Given this list of marker genes Rpl6l, Rpl36a, Rpl39l, Rpl11, Rpl34-ps2, Rpl31, Rpl22, Rpl18a, Rpl36, Rpl8, Rpl32-ps, Rpl39, Rplp2-ps1 (NCBI Gene Id 676643), Uba52-ps, Rpl21, Rpl9, Rpl14, Rpl38, Rpl41, Rpl34-ps1, Rpl5, Rpl13-ps6, Rpl10-ps3, Rpl10, Rpl36al, Rpl24, Rpl3l, Rpl4 (ribosomal protein L4), Rpl10a, Rplp1, Rpl30, Rpl35, Rps12, Rpl17, Rpl17-ps8, Rpl6, Rpl9-ps6, Rpl28, Rpl32l, Rpl35a, Rplp0, Rpl37, Rpl23, Rpl27rt, Rpl34, Rpl9-ps1, Rpl7, Rpl13, Rpl35rt, Rpl7l1, Rpl27a, Zcchc17, Rpl27, Rpl23a, Rpl18, Gm6525, Rplp2, Rpl3, Rpl29, Gm6133, Rpl37a, Rpl15, Uba52, Rpl12, Rpl32, Rpl13a, Rplp1rt, Rpl19, Rpl37rt, Uba52rt (ubiquitin A-52 residue ribosomal protein fusion product 1, retrotransposed), Rpl36-ps12, Rpl26, Rpl7a, Rpl10l, here is a description of the gene set: studied in species Mus musculus The large subunit of a ribosome located in the cytosol. Mouse Gene Set: GOCC_CYTOSOLIC_LARGE_RIBOSOMAL_SUBUNIT